Given this list of marker genes UCHL1, PSMD3, NEDD4, PSMB6, PSMA5, UBE2B, UBC, PSMA3, PSMC1, H2AC4, PSMC2, PSMD6, PSME3, PSMB1, PSMB9, PSMB4 (NCBI Gene Id 5692), UBA1, UBE2D1, PSMD5, HLA-F, UBE2D2, UBA7, HLA-G, PSMA7, PSMB8, PSME2, PSMC6, UCHL3, PSMB7, PSMA2, HLA-A, PSMC3, PSMB10, PSMC5, PSME1, RPN2, PSMB3, PSMD7 (proteasome 26S subunit, non-ATPase 7), PSMB5, RPN1, HLA-E, UBB, UBE2D3, PSMA6, HLA-B, PSMD11, PSMD8, PSMD10 (NCBI Gene Id 5716), PSMD12, H2AX, PSMD1, PSMD4, PSMB2, PSMD13, IFNG, H2AZ1 (NCBI Gene Id 3015), PSMD9, PSMD2, HLA-C, PSMA1, PSMA4, PSMC4, here is a description of the gene set: studied in species Homo sapiens Proteasome degradation Human Gene Set: WP_PROTEASOME_DEGRADATION